Given this list of marker genes Llgl1 (NCBI Gene Id 16897), Yap1, Tcim, Cc2d1a, Gata2, Tspan5, Hif1an, Bend6, Dlk1, Cntn6, Jag1, Lfng, Mmp14, Adam10, Egfl7, Nrarp, Mfng, Nle1, Zbtb7a (NCBI Gene Id 71606), Bmp2k, Gdpd5, Ccn3, Stat3, Rian, Postn, Gata5, Ovol2, Dlk2, Slc35c1, Neurl1a, Pofut1, Enho, S2bpcox16, Mettl3, Dicer1, Tm9sf5, Chac1, Robo1, Llgl2, Mesp1, Yjefn3, Prag1, Tspear, Notch4, Gsx2, Il6st, Wnt1, Slc35c2, Hey2, Ascl1, Synj2bp, Dtx1, Rfng, Tspan15, Robo2, Kctd10, Hes5, Fgf10 (fibroblast growth factor 10), Arrdc1, Nfkbia, Dlx2, Cdk3, Cbfa2t2, Src, Cc2d1b, Nod2, Dll4, Dll3, Zmiz1, Aak1, Dll1, Ythdf2, Trp63, Pdcd10, Gdf2, Sox2, Hes1, Bcl6, Galnt11, Lrrk2, Bmp7, Herc2, Hey1, Rita1, Dlx1, Reck (NCBI Gene Id 53614), Ccnc, Srebf2, Cd46, Tspan14, Tgfb2, Itgb1bp1, Gas2, Arrb1, Kit, Epn2, Jag2, Nepro, Acvrl1, Notch1, Poglut1, here is a description of the gene set: Mouse Gene Set: GOBP_REGULATION_OF_NOTCH_SIGNALING_PATHWAY Any process that modulates the frequency, rate or extent of the Notch signaling pathway. species: Mus musculus